The following is a description of a gene set: Human Gene Set: GOBP_HEAD_DEVELOPMENT species: Homo sapiens The biological process whose specific outcome is the progression of a head from an initial condition to its mature state. The head is the anterior-most division of the body., and this is the list of marker genes: RARB, CLP1, CCDC14, SIRT2, MEIS3 (NCBI Gene Id 56917), CDH2, POU3F1, AVPR2, AHI1, FEZF1, PBX3, SMARCA1, SLC6A3, SYNGR3, PAK1, FZD1, WNT1 (Wnt family member 1), CDK5R2, PALS1, SCX, HOXA2, KRAS, LRP8, CWH43, TRAPPC9, NEUROD2, HPRT1, NOG, DLX1, UBB, RAB18, MMP2, NOTCH2NLC, ANAPC7, CCKAR, CFAP43, KCNC2, CHD8, ATRX, COL4A1, DHX37, NOTO, ATP1B2, STIL, C2CD3, INHBB, RAN, FOXO3, MBOAT7, RBBP4, PTEN, MAFB, SLIT2, ROBO2, BTBD3, CLN5, TOX, PSMG1, IER3IP1, DSCAML1, KCNA2, SEC16A, GRIN2D, COL3A1 (NCBI Gene Id 1281), CDK5RAP2, ASPH, MYH3, NDUFS4, SEMA4C, AKT3, GMPPA, ENSG00000274276, ATP2B4, NDNF, ASCL1, METTL3, EMX1, VCX3A, MECP2, ARHGAP11B, SECISBP2, LHX2, AVPR1A, BMP7, PTPN11, IFT172, SPHK2, PHF8, FANCD2, TGFB2, NME7 (NME/NM23 family member 7), TUBB2B, MINK1, WNT7B, ALDH1A2, PHOX2B, E2F1, PTBP2, ZNF430, SUDS3, CENPF, HOXB1, PITPNM1, CREB1 (NCBI Gene Id 1385), BASP1, SLC32A1 (solute carrier family 32 member 1), DLL1, KDM7A, PRDM13, CASP5, TRNP1, RAC1, SEMA6B, SLC4A10, COL1A1, HTR5A, MAG, FAT4, ITGAM, NTRK2, TMEM108, DDX10, KDM6B, DIXDC1, GPR37L1, DMRTA2, SHROOM4, CHRNB2, OGDH, NUMBL, HSPG2, TBX3, CNTN4 (contactin 4), ANKRD11, POMGNT1, SEMA5A, DLX6, RAF1, NUMB, AMIGO1, DDIT4, NDEL1, RTN4, SUN1, EPHB2, UCHL5, OPHN1, AK8, PITX3, HDAC1, PPP1R9B, COQ8B, GHRH, PROX1, HIF1A, PAX2, FOXG1, PHGDH, CDK5RAP3, TIPARP, CCDC141, POMK, NRXN1, VAX1, MCPH1, CSNK1D, PAX6, GRIN2C, LHX1, CHD7, HYDIN, RTN4R, AFG2A, TRA2B, WNT4, NDUFS3 (NCBI Gene Id 4722), FEZF2, CDON, PCM1 (NCBI Gene Id 5108), ASPM, PLXNA1, UBE3A, NRCAM, RAPGEF2, SOX2, GHRHR, SLC1A2, OTP, LAMB1, MMP14, SOX9, COMT, SOX3, BTG2, SKI, GPX4, MAP2K1, BBS1, GAS8, FLVCR1, TYRO3, C12orf57, FBXO41, LDHA, GRIN2B, OLIG2 (oligodendrocyte transcription factor 2), TUBB2A, SFRP1 (NCBI Gene Id 6422), LHX5, NPY, SOS1, ANP32B, FXR1, ATP5PB, PCDH9, EPHB3, FGF13, PITX2, WDR89, HES5, SLC25A46, WDR11, NEUROD1, TBX1, H2BC12L, CRH, INTS15, RRAS, CALM2, WNT3A, DOCK7, INA, FCGR2B, UGP2, NODAL, LARGE1, ZDHHC16, NDE1, KDM4B, RERE, BMP4, P2RY12, OTX2, RTN2, OSR2, EGFR, KCNA1, EFHC1, SLC6A17, MKKS, POMT2, NOTCH3, RTN4RL1, LIMK2, SOX14, TBC1D23, FLRT3, LHX8, SPTBN2, AMIGO3, TGFB1, FZD3, SRD5A2, CIC, GRIN1, CORO1C, SLC8A3, RHOA, DNAAF3, AATK, VPS51, NDRG2, DIAPH3, NAPA, RTN1, GIT1, GDF10, TBR1, CCDC85C, PPT1, TRABD2A, SELENOP, CHD5, SCN5A, SYPL2, HESX1, SLC7A11, NAGLU, UTP3, ATG16L1, WHRN, VAX2, SOX15, RBPJ, LEF1 (lymphoid enhancer binding factor 1), UPF3B, CSNK2A2, APLP1, NANOS1, EOMES, SERPINE2, BMI1, WDR62, FOXP1, PEX13, RARA, STXBP3, DRD2, ZIC2, WLS, KCNC1, SHROOM2, EXT1, HOXB2, AFF2, FAIM2, IGF1, CALM1, RARG, GNPAT, UQCRQ (ubiquinol-cytochrome c reductase complex III subunit VII), FOXC1, MYO16, ZNF148, POU3F3, CTNS, FXR2, PDGFRA, NOTCH1, CBLN1, PYGO2, APAF1, S1PR1, NEUROG2, ODAD4, CDK5, MEIS3P1, FOXJ1, BCL2, XRCC1, EPHB1, SLITRK5, MYH10, WDR47, NKX2-6, TTLL1, GATA2, IL11RA, KIF14, PRKDC, CBS (cystathionine beta-synthase), KLHL1, ISL1, RAB3GAP1, NCOA1, IHH, SEC24B, NKX2-1, TFAP2C, MDK, CKB, CDC42, SRF, SRGAP2C, ZIC1, KAT2A, BRAF, TSC1, EZH2, NEFL, PEX5, PHLPP2, NEUROG3, CCDC32, ARID5B, GRHL2, EPHA5, SKOR2, NLGN4X, SIN3A, TWSG1, NR4A3, HMGA2, GSX2, BMERB1, SEMA3A, GBA1, ARL13B, POU4F1, CEP290, DAB2IP, NR0B1, HSD17B7, NHLH2, JHY, YWHAH, UFM1, MT-ND4, CALM3, ALK, SPEF2, OTX1, PADI2, ABAT, TMEM14B, WNT3, TULP3, AMIGO2, NAV2, ODAD2, B2M, KIRREL3, SSBP3, ATAT1, CRISPLD1, CITED1, TUBGCP2, PAX5, ALDH1A3, DNAH5, GLI2, ATOH1, SMG9, ROGDI, ARNT2, BRCA2, SLC38A2, ATP1A2, LPAR1, BGLAP, SEZ6, MAPKAP1, CNTNAP2, VCY, SLC23A1, POTEE, METTL14, MAP2K2, ATF5, MEIS2 (NCBI Gene Id 56908), SOX4, DLC1, CFL1 (cofilin 1), HOOK3 (hook microtubule tethering protein 3), TACC1 (NCBI Gene Id 6867), CELSR2, SCYL2, CXCR4, POU3F2, DNAJB1 (DnaJ heat shock protein family (Hsp40) member B1), GABRB3, SRD5A1, TFAP2D, DLG5, ATF2, MNAT1, WNT7A, TTC21B, UFC1, TAL2, SUN2, SZT2, PHACTR1, CNP, MACROH2A2, FBXW11, NIPBL, SLC6A4, SHANK3, FKRP, PLXNB2, BPTF, LHX6, NEUROG1, NRGN, PRDM8, BAG6 (BAG cochaperone 6), EIF2B5, FGF10, UNC5C, FGFR1, ATRN, TOP2B, ADGRG1, FOS, TACC2, NDST1, DLX2, AQP1, AKNA, FKTN, EN1, CEP120, YWHAQ, EML1, BCAN, POU1F1, SLIT1, NARS1, WNT2, RORA, COL2A1, RBBP7, SRGAP2, TAF1, GNB4, SOX12, AGTPBP1, CMA1, SOX11, EN2, TBX19, PHOX2A, MDGA1, PSEN1, LRP6, DNAJC30, ID2 (inhibitor of DNA binding 2), COX6B1, MSX1, ODAD3, MBP, EPOR, HOXB3, DRAXIN, CRISPLD2, PDSS2, ZSWIM6, DISC1, RAD1, GLI3, CDK5RAP1, NRG1, XRN2, SCT, NRP1, HSPA5, GRID2, CSRNP1, PGAP1, SLIT3, VCX2, PTCH1, NF1, FRS2, VCY1B, CTNNA2, EZH1, KDM2B, WNT5A, SDF4, HNRNPD, SCRIB, ELAVL4, PCDH18, RAX, SEMA6D, NR4A2, CLDN5, CTNNB1, PIANP, AXL, CRTAC1, PLCB1, SSTR1, PFAS, KNDC1, SRC, NKX2-2, TP73, FILIP1, NCOA6, AARS1, CNTN1, VCX, TSKU, VPS13B, NR2F2, LMX1A, B4GALT2, VCX3B, BRINP1, ABL1, PLXNA4, DKK1, NCOR2, TYROBP, BNIP3, CRKL, AIM2, ATP6AP2, ACTB (NCBI Gene Id 60), SOCS7, GBX2, ZMIZ1, PAX4 (NCBI Gene Id 5078), MATCAP1, HNF1B, APOD, PLXNA2, YWHAE, HTR6 (NCBI Gene Id 92230), FEZ1, TUBA1A, ARHGAP35, CNTN2, ABCB6, SYNE2, TGFBR2, NFASC, FOXB1, ARCN1, MED1, ARL6, PAFAH1B1, MEIS1, NR2E1, ATXN1, SMAD1, FGF2, SFRP2, C21orf91, QARS1, SMO, UNCX, NRP2 (NCBI Gene Id 8828), KIAA0319, FGF9, ZFAND5, HMX3, NIN, ID4, STRA6, SEMA3E, CRK, MAP1S, PBX4, XAB2, BMP5, MAST1, BAX, LRP2, GART, MAPK3, ERBB4, CNTN5, DYNLL1, DYNC2H1, NRG3, PROP1, WDR37, IGF2BP1, RFX4, NFIB, SPHK1, BBS4, ATXN1L, FLNA, LHX3, SOX21 (NCBI Gene Id 23490), KIF26A, RAC3, NES, KCNE1, WNT2B, BBS7, PLP1, PTF1A, EDNRA (NCBI Gene Id 1909), GDF7, BCL11B, DAB1, TACC3, TTBK1, CA10, FBXO45, LDB1, NOTCH2NLB, CASP3, FYN, NEUROD6 (NCBI Gene Id 63974), SIX3, GSX1, CX3CR1, RYK, TGFB3, IRS2, HMX2, GSC, BARHL1, PITX1, PAX9, B3GLCT, MAOB, FOXP2, EEF1AKMT4-ECE2, MT-CO1 (mitochondrially encoded cytochrome c oxidase I), EP300, ATIC, GIT2, BBS2, GPR158, POU3F4, AGTR2, DMBX1, FOXR1, G6PD, MACROD2, FGFR2, CDK5R1, MGARP, RELN, BLOC1S6, SGPL1, CDH1, MKS1, CEND1, MACO1, HAP1, MAPK1, NF2, PBX2, GLUD1, PRICKLE1, PTCHD1, FZD4, NCSTN, AKIRIN2, BMP2 (bone morphogenetic protein 2), FZD6, CD3E, DCT, DRD1 (dopamine receptor D1), NNAT, ZIC3, ATM, SOX1, SEMA7A, ATP5PF, TP53, KIF27, MFSD2A, ZNF365, HTRA2, RRM1, SLC1A1, SLC2A1, DPCD, TNR, FUT10, BCR, ZEB2, TCTN1, TTC8, EFNA2, RTN3, CCDC39, BMPR1A, ARX (NCBI Gene Id 619216), STK36, TMX2, ROBO1, SOX6, HERC1, WNT9B, EGF, EMX2 (NCBI Gene Id 2018), ATP7A, RTN4RL2, NSUN5, EPHA7, ITGB1 (NCBI Gene Id 3688), FUT1, PLEKHA1, CERS1, PRKG1, CSF1R, CDK6, HES1, INHBA, SHH, PLXNA3, GSK3B, CXCL12, DLX5, ZNF335, GRIN2A, KDM1A, DCLK2, PBX1, SALL1, NEGR1, AXIN1, CCDC134, POU6F1, RPGRIP1L, GRIA1, PTPRS, NOTCH2NLA, TTBK2, S100A1, GLI1, IMMP2L, FGF8 (NCBI Gene Id 2253), LRRK2, EGR2, SETD1A, NME5